The following is a description of a gene set: species: Homo sapiens Human Gene Set: WP_GENE_REGULATORY_NETWORK_MODELING_SOMITOGENESIS Gene regulatory network modeling somitogenesis, and this is the list of marker genes: FGF8, WNT3A, MESP2, TBX6, HES1, DLL1, HES7 (NCBI Gene Id 84667), RIPPLY2, NOTCH1, EPHA4, LFNG